The following is a description of a gene set: electronically inferred by orthology from the curated human pathway This event has been computationally inferred from an event that has been demonstrated in another species.<p>The inference is based on the homology mapping from PANTHER. Briefly, reactions for which all involved PhysicalEntities (in input, output and catalyst) have a mapped orthologue/paralogue (for complexes at least 75% of components must have a mapping) are inferred to the other species. Reactome Pathway: WNT5A-dependent internalization of FZD4 species: Mus musculus part of: PCP/CE pathway, and this is the list of marker genes: Arrb2, Ap2b1, Ap2m1, Prkca, Ap2s1, Ap2a1, Dvl2, Cltb, Fzd4, Prkcg